Given this list of marker genes DLX1, REM2 (RRAD and GEM like GTPase 2), IL25, FAM117A, NEUROG1, BCORP1, DLG2, ITPR3, DMD, MT-CO1, KRTAP13-2, APOBEC4, POLDIP3, HOXA7, PROKR2, CDX4, EML1, RAB30, TSC1 (NCBI Gene Id 7248), SUGP2, KANSL1L, OR8B8, FZD4 (frizzled class receptor 4), CNNM4 (cyclin and CBS domain divalent metal cation transport mediator 4), NXT2, NFYB, NEDD4, LHX6, LPL, SLC25A12, GCM1, NRXN1, CCN1, H2AC4, SNCAIP, CLCA3P, TMSB4XP8, BMP5, POU2F3, E2F3, TAS2R40, PIM2, ARMC6 (NCBI Gene Id 93436), PRDM10, SASH1, EGR2, KRTAP8-1, C10orf71, JARID2, TEAD3, H2BC12, THRA, KIF13A, DPYSL3, IRX4, TAS2R13, KCNN3, ARMCX4, SLC6A15, STXBP6, LYN, CBFA2T2, ADNP2, PLEKHA6, PRICKLE2, ADORA2A, CBFA2T3, KLHL1 (kelch like family member 1), GRHL3, DPYSL2, ZC3H14, HOXA10, SH3BGRL, FSTL5, PMEL, AMER1, TCEAL9, DGKG, BARHL2, JCHAIN, SLITRK2, ARHGAP4, ESRRA, SLC1A2, SIAH3, CCDC107, ZIC3, PLPPR2, COL25A1, POU2F1, HOXD11, ADGRL1, CDR2L, H2AC17, C2CD5, ETV1, JUND, PLXNA2, NEDD9, FCHSD1, VSNL1, NR2E1, YBX3, EGLN2, IKZF2, TSNAX, H2AC20, TMSB4XP2, EPHB3, PCYT1B, ADNP, HOXA3, PPP2R3C, CRYZL1, RANBP3L, NOL4L, TLL2, SLC39A13, MYBPC1, TTI2, TMCC1, RAB26, PAX6, CD40LG, LMO3, TNFRSF9, SRF, VPREB3 (V-set pre-B cell surrogate light chain 3), HNF1B, ING1 (NCBI Gene Id 3621), TRAF3IP2, H3-3B, OTX2, PER2, MANF, PRRC2A, GAP43, H2AC6, ZNF362, H2AC12, ABL1, PCDH8 (NCBI Gene Id 5100), HOXC11, ROGDI, SYNPR, SCOC, PDE4D, SEMA7A, DSE (dermatan sulfate epimerase), HOXB8, NFIA, CLRN1, GAB2, ABTB2, PPP2R3A, TMSB4XP6, MMP1, ITSN1, ZNF428, H2BC26, PATZ1, ALK, EBF1, CHD6, SFRP2, MAP2K6, SEMA6C, LRCH4, DTNA, BCL2, UBE2S, H2BC17, BST2, CADM1, ZBTB20, SESN3 (NCBI Gene Id 143686), EMILIN3, H3C3, H2BC4, NRAS, CDH10, CDK14, HOXB3, ASCL3, TLE3 (TLE family member 3, transcriptional corepressor), H3C2, MTUS1, SUCNR1, PRDM1, GALNT1, KCNT2, KCTD6, HOXD4, H2AC25, MAB21L2, CDK2, ALDH1A1, GNA14, TMOD2, HDAC9, FGF14, MRAS (muscle RAS oncogene homolog), TMSB4XP4, C12orf57, LDB2, GPM6A, OR10A5, SP6, SLC10A2, ISL1, TSPAN13, FGFR2, FBXL14, PFKFB1, SIX1, BLNK, SMPX, SKIDA1, SLC25A35, LCOR, GPR4, FBXO24, GRIA3, EHF, SALL1, TSC22D3, NRL, SFRP1, DLGAP4, H2BC3, SH3GL3, PTEN, ADORA1, FGF20, ZHX2, LRRN1, NR1D1, SLC26A7, RRAS, BSND, HOXC5, MIR9-1HG, TBXAS1, OPA3, CRISP1, OR10J1, SEC22A, SREBF2, FOXG1, GRID2, MIR17HG, GCNT2, PRRX1, SERTAD4, UQCC2 (ubiquinol-cytochrome c reductase complex assembly factor 2), MT-CO2, MSI2, STAT4, REL, POU3F4, CSF3 (NCBI Gene Id 170794), MT-ND2, CSRNP3, TCF7L1, WWC2-AS2, FGF12, RCAN1, MMP17, CADM2, RHOB, here is a description of the gene set: species: Homo sapiens Genes having at least one occurrence of the motif CTNATTTGCATAY in the regions spanning 4 kb centered on their transcription starting sites. This matches the transcription factor binding site V$OCT_C (v7.4 TRANSFAC). Human Gene Set: OCT_C